The following is a description of a gene set: species: Homo sapiens Binds to and modulates the activity of the enzyme ornithine decarboxylase. Human Gene Set: GOMF_ORNITHINE_DECARBOXYLASE_REGULATOR_ACTIVITY, and this is the list of marker genes: AZIN1, AZIN2, OAZ3, OAZ1, OAZ2 (ornithine decarboxylase antizyme 2)